Given this list of marker genes PARP4, PARP10, NAXE, SLC22A13, PARP16, PARP9, NUDT12, PARP14, NAXD, NAMPT, SLC5A8, RNLS, PARP8, NAPRT, NNMT, PARP6, here is a description of the gene set: Nicotinamide salvage studied in species Homo sapiens Human Gene Set: REACTOME_NICOTINAMIDE_SALVAGE